Given this list of marker genes ALDH3A2, HACL1, PHYH, SLC27A2, SLC25A17, PECR, here is a description of the gene set: part of: Peroxisomal lipid metabolism Phytanic acid arises through ruminant metabolism of chlorophyll and enters the human diet as a constituent of dairy products. It can act as an agonist for PPAR and other nuclear hormone receptors, but its normal role in human physiology, if any, is unclear. It is catabolized via a five-step alpha-oxidation reaction sequence that yields pristanoyl-CoA, which is turn is a substrate for beta-oxidation. These reactions take place in the peroxisomal matrix and their failure is associated with Refsum disease. Reactome Pathway: Alpha-oxidation of phytanate studied in species Homo sapiens